The following is a description of a gene set: Human Gene Set: REACTOME_SIGNALING_BY_FGFR4 Signaling by FGFR4 studied in species Homo sapiens, and this is the list of marker genes: FGF1, MAPK3, FGF2, PPP2R1A, FGF8, PLCG1, FGF19, MKNK1, KRAS, PIK3CA, SPRY2, SHC1, BRAF, UBC, PPP2CB, PPP2CA, HRAS, FGF17, FGF6, FRS3, KLB, GAB1, SRC, MAPK1, FGF18, FGF4, FGF23, FGF16, UBB, PIK3R1, NRAS, UBA52, FGF20, FGF9, PTPN11, SOS1, GRB2, RPS27A, FGFR4, FRS2, CBL